Given this list of marker genes OPN1MW, here is a description of the gene set: species: Homo sapiens Normal human colour vision is trichromatic, based on 3 types of cones that are maximally sensitive to light at approximately 420 nm (blue cones), 530 nm (green cones), and 560 nm (red cones). Neural circuits compare light absorbed by these 3 cone types to perceive those primary colours and combinations of them. Colour vision deficiencies result from genetic mutations that affect the expression of the full complement of cone photoreceptors and are classified by severity of deficiency (see reviews Deeb 2005, Simunovic 2010).<br><br>Deutan colourblindness (DCB, deuteranopia, partial colorblindness, green colourblindness; MIM:303800) is caused by mutations in the OPN1MW gene which encodes green cones. In European populations, red-green colourblindness is prevelant in 8% of males and 0.5% of females. This frequency is lower in non-European populations.<br><br>Defects in OPN1MW also cause X-linked cone dystrophy type 5 (COD5; MIM:303700), a retinal dystrophy characterized by progressive degeneration of cone photoreceptors but with preserved rod function. Reactome Pathway: Defective visual phototransduction due to OPN1MW loss of function part of: Retinoid cycle disease events